Given this list of marker genes OSBPL11, ACLY, SNRK, NMI, HOPX, TRAF3, CCNT2, FAM8A1, TNFRSF25, GALE, DYRK2, SACS, TEX10, RPL41, TUBGCP6, SAMD9L, KXD1 (KxDL motif containing 1), CPEB4, AFG2B, EPSTI1, HNRNPDL, LIG4, NMT1, EIPR1, XXYLT1, TNFRSF4, RRP7A, TPRA1, VCPKMT, TMEM129, LGI3, IL4R, FAAH, RRP36, RBM45, PPP4C, SDCBP2, NUP43, RAD17, CSNK1G1, AZI2, CLCN4, RMND1, GINM1, ZYG11B, AAK1, SUSD6, AGPAT3, MRPS12, CDK11B, CDR2, VPS29, VPS54, RHOF, ANG, SPP1, NPC2, CRTC3, ABHD8, DKK3, INTS15, RGS11, GNGT2, CLXN, CPM, BCL6, LYST, PEDS1, MED11, TNKS2, COPE, AGFG2, TOX4, SEC11A, MIEN1, KRIT1, EPC2, TULP4, NTRK3, LMAN2L, MRPS24, SRA1, CLDN10, DDOST, RCVRN, TBC1D4, DHRS7, HIGD2A, ADGRA1, STAT3, MSS51, AFP, ATPSCKMT, ZBTB8OS, TRAPPC1, SZT2, CHFR, DERL2, CFP, DNAJC3, C11orf68, INTS11, POGZ, CCNDBP1, KRT13, PITPNM2, TNFRSF18, MRPL24, NIBAN1, PPP1CA, C3orf80 (chromosome 3 open reading frame 80), ABHD17A (NCBI Gene Id 81926), PPCDC, GPR183, HERPUD2, SORCS2, MIA3, HEXB, KLRG1, RPL18A, PPP1R17, RNF167, STK4, NDUFA6, RNF19A, SPICE1, TTC14, RHOG, NEK7, PRKCH, PLTP, SLC20A1, ARHGAP30, GAK, NSD3, SF3B5, PSPH, ATOSA, ARID5B, MARF1, SAMM50, TMA7, LRIF1, PGLYRP1, STAT1, CHURC1, MED28 (NCBI Gene Id 80306), PIGO, MRPL20 (mitochondrial ribosomal protein L20), NLRC3, DNAJA4, RAP2B, TPP2, MPHOSPH9, CAPN1, IL27RA, UBL4A, SLFN13, WDR59, CRADD (CASP2 and RIPK1 domain containing adaptor with death domain), SESN3, CYB561D2, PPP2R5A, BRMS1, EPC1, SAG, SEMA3C, FYCO1, CD37, BAX, RNF114, NUP210, NPRL2, L1CAM, PTPN6, ZNF707, LY9, FGD3, MAD2L1BP, SRD5A3 (NCBI Gene Id 79644), DYNLRB1, AMN, PLD3, USP34, TAF4B, MRTFA, FOXJ3 (forkhead box J3), LIMK2, MCUB, FAM50A, POU2AF1, ESCO1, ZBTB6, INTS8, GBA1, TBX21, PGAP1, JMJD7-PLA2G4B, CTSW, here is a description of the gene set: Genes down-regulated in naïve macrophages: untreated versus LPS. studied in species Homo sapiens Among the multiple mechanisms that control the intensity and duration of macrophage activation, the development of a state of refractoriness to a second stimulation in cells treated with LPS has long been recognized. Release of inhibitory cytokines and alterations in intracellular signaling pathways may be involved in the development of LPS tolerance. Although a number of molecules have been implicated, a detailed picture of the molecular changes in LPS tolerance is still missing. We have used a genome-wide gene expression analysis approach to (i) define which fraction of LPS target genes are subject to tolerance induction and (ii) identify genes that are expressed at high levels in tolerant macrophages. Our data show that in LPS tolerant macrophages the vast majority of LPS-induced gene expression is abrogated. The extent of tolerance induction varies for individual genes, and a small subset appears to be excepted. Compared to other negative control mechanisms of macrophages, e.g. IL-10-induced deactivation, LPS-tolerance inhibits a much wider range of transcriptional targets. Some previously described negative regulators of TLR-signaling (e.g. IRAK-M) were confirmed as expressed at higher levels in LPS-tolerant macrophages. In addition, we discuss other potential players in LPS tolerance identified in this group of genes. from publication Mages J, Dietrich H, Lang R (PMID 18086374) Human Gene Set: GSE8621_UNSTIM_VS_LPS_STIM_MACROPHAGE_DN